Given this list of marker genes Slc15a4, Enpp1, Tnfrsf13b, Fcer1g, Vpreb1a, Mef2c, Gpam, Bcl2a1a, Ahr, Hif1a, Gimap5, Stat5b, Lipa, Pde4b, Ada, Chst3, Rc3h2, Sh2b2, Cd44, Foxn1, Stat5a, Nf1, Il18, Mertk, Bbs4, Slc40a1, Foxp3, Tnfsf13b, Nckap1l, Kitl, Spta1, Tsc22d3, Rc3h1, Abl1, Adam17, Il2ra, Ppp3cb, Slc37a4, Fadd, Lyn, Sash3, Il2, Gpr15lg, Tnfsf4, Csf1r, Ripk3, Ikbkg, Men1, Il7r, Pik3cb, Hc (hemolytic complement), Dock11, Ppp2r3c, Vpreb1b, Cfh, Bak1, Cxcl5, Ccnb2, Gpr183, Gpr174, Tcirg1, Ppp2r1a, Hcar2, Siva1, Cd47, Fcgr2b, Btk, Mif, Lmo1, Ikbkb, Tgfb1, Bcl10, Zc3h8, Casp3, Mthfd1 (methylenetetrahydrofolate dehydrogenase (NADP+ dependent), methenyltetrahydrofolate cyclohydrolase, formyltetrahydrofolate synthase), Ifng, Tnfrsf4, Dnaja3, Bax, Caml (NCBI Gene Id 12328), Aim2, Bcl2, Akt1, Pik3cd, Wdr37, Spns2 (NCBI Gene Id 216892), Gapt, Xkr8, Pacs1, Nkx2-3, Mecom, Tnfrsf17, Sos2, Tspan9, Jam3, Skil, Lilrb4a (NCBI Gene Id 14728), Bbip1, Fas, Dock10, F2r, Ccl2, Traf3ip2, Mir142hg, Jak3, Rps6, Sh2b3, Sos1, Gimap3, Axl, Flt3, Anxa1, Gcnt4, Csf1, Ppp2ca, Slc46a2, Hmgb1, Tnfaip3, P2rx7, Pkn1, Il20rb, Cd74, Mpl, Bcl2l11, Lat, Prdx2, Sit1, Cd24a, Pmaip1, Slc7a11, Itpkb (inositol 1,4,5-trisphosphate 3-kinase B), Cxcr2, Fam3d, Tgfb2, Bap1, Coro1a, Lgals2, Rag1, Ccr2, Tnfrsf13c, Il3, Il6, Slc39a3, Pirb, Itgam, here is a description of the gene set: species: Mus musculus Mouse Gene Set: GOBP_LEUKOCYTE_HOMEOSTASIS The process of regulating the proliferation and elimination of cells of the immune system such that the total number of cells of a particular cell type within a whole or part of an organism is stable over time in the absence of an outside stimulus.